Given this list of marker genes XPO7, DRG1, AFG3L2, EIF4H, POLR2A, MDH1 (malate dehydrogenase 1), TARDBP, DAXX, TRAPPC3, ICE1, PWP1, CAPZA1, SMNDC1, UBE2L3, KXD1, HNRNPM, PRPF31, BZW1, EIF2S2, PSMA4, TXLNA, LRPPRC, RTCB, XPO6, KHDRBS1, EIF1AX, SMS, GAK, IMMT, ARCN1, SNRNP200, PPP2CA, RTN4 (NCBI Gene Id 57142), DEK, DDB1, MTOR, RAD21, HNRNPA2B1, SSBP1, STARD7, HSPA8, HNRNPAB, SUMO2, GPN1, AATF, NUP62, ZPR1, METAP1, AP3D1, BRD8, NONO, SSB, ILF2, PSMB2, DNAJC8, ARPC5, CTDNEP1, CS, HDAC2, POLR2I, GPAA1, ZZZ3, YWHAQ (NCBI Gene Id 10971), PUF60, TIAL1, NUP188, KARS1, SDHA, CUL1, HNRNPU, DHX38, SART3, here is a description of the gene set: studied in species Homo sapiens Neighborhood of CUL1 Neighborhood of CUL1 cullin 1 in the MORF expression compendium Human Gene Set: MORF_CUL1